The following is a description of a gene set: Human Gene Set: E2F1_Q4_01 species: Homo sapiens Genes having at least one occurrence of the motif TTTSGCGSG in the regions spanning 4 kb centered on their transcription starting sites. This matches the E2F, TFDP1 transcription factor binding site V$E2F1_Q4_01 (v7.4 TRANSFAC)., and this is the list of marker genes: RPS6KA5, RANBP1, SMG1, USP49, PRMT3, ATRX, CASP2, JPH1, STK35, POLA2, DNMT1, NUP155, CTNND2, RBPJ, PHF13, MCM4, FBXO9, RPS19, PIK3R4, TRMT13, MEIS2, DNAJC11, ZDHHC17, PCLAF, CDK1, ARHGAP36, MCM3, E2F3, GATA3, ZNF565, FBXO5, NHLRC2, SUV39H1, CDC25A, ATAD2, H2AC12, NIPBL, USP2, NCL, SMC1A, NDUFA11, FANCC, SMC2, H2BC12 (NCBI Gene Id 85236), NSD3, JADE1, ATP5MC2, ATE1, JADE2, USP1, ARID4A, ZCCHC8, PTMA (prothymosin alpha), IER5L, RFC1, CTCF, NCOA6, KLF5, KCNA6, MYC, FHIP1B (FHF complex subunit HOOK interacting protein 1B), EPHB1, KPNB1, PCDH7, RELT, THAP8, EVA1B, NASP, SRSF2, MCM7, EZH2, HNRNPA1, GLRA3, SMC6, TBC1D31, DPYSL2, MCM2, BMP7, TOP1, CDC20B, KBTBD7, PIM1, RIBC1, SLC6A4, MAT2A, STMN1, SMAD6, SERBP1, IMPDH2, MTF2, GAPDH, FAM216A, FBXL20, H1-3, TMEM187, DAXX, OTUD7B, GINS3 (NCBI Gene Id 92916), NECTIN1, NRP2, HOXC10 (homeobox C10), DCK, FMO4, DDB2 (NCBI Gene Id 1643), AP4M1, MXD3, MCM6, UCHL1, CCNT2, OSBPL7, INTS7, ID3, H2BC10, IPO7, MAZ, TBX6, RAD51, YBX2, TRMT2A, SLC16A2 (solute carrier family 16 member 2), RHD, SIK2, STAG1, CASP8AP2, WEE1, RALY, HNRNPD, ITGA1, UXT, CTDSPL2, ANKHD1-EIF4EBP3, DCTPP1, GPN3, ZNF687, SSU72 (NCBI Gene Id 79588, SSU72 homolog, RNA polymerase II CTD phosphatase), KDM3A, PCYT2, DMRT1, BRMS1L, CSRNP1, ELAVL2, SREK1, H2AZ1, RHCE, CDC45, AGFG2, SLC38A1, UFD1, LUC7L3, NUMA1, PAN2 (poly(A) specific ribonuclease subunit PAN2), NR3C2, ING3, YWHAQ, SIN3A, RAB11B (NCBI Gene Id 9230), DOLK, NFATC2IP, GPAT2 (glycerol-3-phosphate acyltransferase 2, mitochondrial), CBX5, DCLRE1A, ERF, TRMT6, SMC3, SALL1, PKMYT1, PELO, TOPBP1, TNPO2, ZNF362, DNAJC5G, CDC6, SEMA5A, DMD, ARHGAP11A, GMNN, POLE2, MCM8, PRPS1, KCND2, EGR3, PPP1R8, STT3B, PCSK1, MAP4K1, FANCG, EIF3K, KMT5A, TLE4, STAG2, PIK3R3, ERBIN, HOXA9, ARHGAP6 (NCBI Gene Id 395), SASS6, CHGB, E2F8, OVOL2, POLA1, MELK, WDR62, ZNF367, NEGR1, PATZ1, LRTOMT, SRSF1, NUP153, PCNA, PRKDC, GEN1, PRRC2C, DDX17, ASXL2, PODN, POLE4, UNG (NCBI Gene Id 7374), DHX40, ACBD6, HMGN2, PPRC1, PPP1R9B, ADAMTS2, HMGA1, CDCA7, INSM1, ZMYM2, ANKHD1, PAQR4, E2F1